Given this list of marker genes ERCC6, DDX21, MYO1C, BAZ1B, SF3B1 (NCBI Gene Id 23451), SMARCA5, DEK, MYBBP1A, here is a description of the gene set: A chromatin remodeling complex that positively regulates histone H3 acetylation, in particular H3K9, by recruiting histone acetyltransferases to rDNA gene regions. Located in the nucleolus where it assembles on RNA Polymerase I (Pol I) and possibly on RNA Polymerase III (Pol III) promoter and coding regions during early G1 phase and activates the post-initiation phases of Pol I transcription. May also activate RNA Polymerase II (Pol II) gene transcription. In mammals, B-WICH contains the WICH complex core of BAZ1B and SMARCA5, additional protein subunits and possibly rRNAs. Although it contains several catalytic subunits it is not clear which functions are carried out by the complex itself. species: Homo sapiens Human Gene Set: GOCC_B_WICH_COMPLEX